The following is a description of a gene set: Human Gene Set: GOCC_AMINOACYL_TRNA_SYNTHETASE_MULTIENZYME_COMPLEX A multienzyme complex found in all multicellular eukaryotes composed of eight proteins with aminoacyl-tRNA synthetase activities (abbreviated as: ArgRS, AspRS, GluProRS, GlnRS, IleRS, LeuRS, LysRS, MetRS where RS is the enzyme, preceded by the amino acid it uses as a substrate) as well as three non-synthetase proteins (p43, p38, and p18) with diverse functions. Several of these subunits are known dimers, so the total polypeptide count in the multisynthetase complex is at least fifteen. All of the enzymes in this assembly catalyze the same reaction, the covalent attachment of an amino acid to either the 2'- or 3'-hydroxyl of the 3'-terminal adenosine of tRNA, but using different substrates. species: Homo sapiens, and this is the list of marker genes: QARS1, LARS1, AIMP1, IARS1 (isoleucyl-tRNA synthetase 1), DARS1, RARS1, EPRS1, AIMP2, MARS1, KARS1, EEF1E1